Given this list of marker genes OPN5, OPN3, RHO, OPN1LW, OPN4, RRH (NCBI Gene Id 10692), OPN1MW, RGR, OPN1SW, here is a description of the gene set: Opsins are light-sensitive, 35-55 kDa membrane-bound G protein-coupled receptors of the retinylidene protein family found in photoreceptor cells of the retina. Five classical groups of opsins are involved in vision, mediating the conversion of a photon of light into an electrochemical signal, the first step in the visual transduction cascade (Terakita A, 2005; Nickle B and Robinson PR, 2007). Another opsin found in the mammalian retina, melanopsin, is involved in circadian rhythms and pupillary reflex but not in image-forming (Hankins MW et al, 2008; Kumbalasiri T and Provencio I, 2005). Guanine nucleotide-binding proteins (G proteins) are involved as modulators or transducers in various transmembrane signaling systems. The G protein transducin, encoded by GNAT genes, is one of the transducers of a visual impulse that performs the coupling between rhodopsin and cGMP-phosphodiesterase. Defects in GNAT1 are the cause of congenital stationary night blindness autosomal dominant type 3, also known as congenital stationary night blindness Nougaret type. Congenital stationary night blindness is a non-progressive retinal disorder characterized by impaired night vision (Dryja TP et al, 1996). Defects in GNAT2 are the cause of achromatopsia type 4 (ACHM4). Achromatopsia is an autosomal recessively inherited visual disorder that is present from birth and that features the absence of color discrimination (Kohl S et al, 2002). part of: Class A/1 (Rhodopsin-like receptors) Reactome Pathway: Opsins studied in species Homo sapiens